The following is a description of a gene set: Development of T-cells provides a unique opportunity to study cell-fate determination due to the accessability and the well defined stages of developmental stages. In order to understand the genetic programs underlying fetal and adult T‑cell fate specification we subjected highly purified fetal and adult T-cell progenitor populations to a genome‑wide transcriptional analysis. The aim was to identify molecular elements that govern T-cell fate specification as a whole but ultimately to isolate elements that were specific for a given population in a specific developmental window. Human Gene Set: GSE24142_DN2_VS_DN3_THYMOCYTE_DN studied in species Homo sapiens Genes down-regulated in comparison of DN2 thymocytes versus DN3 thymocytes. from publication Belyaev NN, Biró J, Athanasakis D, Fernandez-Reyes D, Potocnik AJ (PMID 22581009), and this is the list of marker genes: PHLDA1, N4BP2L1, GCOM1, SLC16A1, TRIM46, PRRT1, UTP25 (UTP25 small subunit processome component), SCAF8, TRIB2, HIBADH, ETS2, BTG2, RELB (NCBI Gene Id 5971), DDIT4, AKAP1, RNF19A, SHISA5, SPRY1, SIDT2, PGS1, LEF1, PXMP4, ACAA2, RC3H2, TAF1C, IFT25, CLDN4, CD28, MTSS1, NDEL1, KDM3A, SLC5A9, PCMTD1, LDHB, CD164, SFXN2, CTSV, LCLAT1, AHCYL2, SLAMF6, SNAI3, STT3B, LCK, DNAJC5, PTPRF, EFEMP2, ITK, HMGCS2, PLD3 (phospholipase D family member 3), SH2D1A, PADI4, NSG2, STC1, IRF4, CBL, TPST1, EPB41L4A, MED10, CHD1L, PFN2, TNNI3, MKNK1, NOPCHAP1, GFI1, DENND11, MINPP1, SATB1, CCR9, CTLA4, TRIM11, CHCHD3, PPP2R5A, GRAP2, SOCS3, PTCRA, CD3E, CTSB, AXL, ARHGEF10L, TMEM120B, ITPR1, THNSL2, NDST1 (NCBI Gene Id 3340), SPATS2, DYNLT5, HSDL2, CARD10, F2, BST1, TCF12, DESI1, AKAP12, GFRA1, KDM4B, CPEB4, RAPGEF4 (Rap guanine nucleotide exchange factor 4), ZMAT3, SORCS2, USP3, PLXDC1, FBLN2, TSPYL4, SLC12A7, NFATC1, MARK3, DEGS2, CDKN1B, TCF25, DAPK1, ARHGAP9 (Rho GTPase activating protein 9), ORMDL3, MBP, BRDT, RPS6KL1, KLC3, ANKS3, RNF111, SPIB, CCPG1, PELI1, FKBP5, SENP2, DOP1B, ITPR2, DLG3, TJP3, RRM2B, LYST, FAM234B, TPRKB, SH3KBP1, ARPP21, TMEM50B, MBTPS1, SPATA6, CYB5A, SIT1, TMPRSS4, IL34, CD3G, C1QTNF1, SASH3, NOTCH3, SLC35D1, PLD4, MEF2A, SERAC1, SLC37A1, FAM131A, MBNL3, EDEM1, TMC6, TBC1D8, SLC29A3, AGPAT3, PDPK1, TULP3, SLC37A2 (NCBI Gene Id 219855), EGR1, LLGL2, GSR, CD3D, KCNH2, PMEPA1, FICD, SLAIN1, EPCAM (NCBI Gene Id 4275), ERRFI1, TM6SF1, MGST2, HSD11B1, ADCY6, FBXL12, EXT2, PPP2R5C, RFXANK, PRKCB, ABLIM1, TRAF1, KDM4C, RAG1, RRAS2, RGS10, CAMKK1, NOTCH1 (notch receptor 1), TECPR1, DEGS1, DGKA, HPCAL1, TOLLIP, PPT1, ACTN1, EIF2AK3, TMEM131, BTG1, EGR2, MIA2, ATOH8, GALNT2